The following is a description of a gene set: studied in species Homo sapiens The process whose specific outcome is the progression of a nerve over time, from its formation to the mature structure. Human Gene Set: GOBP_NERVE_DEVELOPMENT, and this is the list of marker genes: SIX4, CITED2, NAV2, HOXB3, GLI3, LRIG1, HES1, NEUROG1, NPR2, CHD7, GABRB3, EPHB1, BDNF, SLC1A3, EDNRA (NCBI Gene Id 1909), EGR2, GABRA5, NAGLU, AFG3L2, SLC24A4, EPHB2, HOXB2 (homeobox B2), SLC25A46, KCNQ3, ILK, NRTN, NGFR, CNGB1, NDP, TBX1, PLXNA3, VCAM1, SLITRK6 (SLIT and NTRK like family member 6), LPAR1, B4GALNT1, DRGX, CTNNB1, FBXO45, DAG1, ATOH7 (atonal bHLH transcription factor 7), KCNA2, NGF, NRP2, POU4F1, PRKCG, PHOX2A, SULF2, NKX2-2, SCN1A, ERBB3, KCNC2, ISL1, POU4F3, PHOX2B, SIX1, SULF1, LARGE1, ACKR3, SEMA3F, LRIG2, DICER1 (dicer 1, ribonuclease III), ECE1, PLXNA4, HOXA3, SLC38A8, HOXA1, NTRK1, ADARB1, EPHA4, CHRNB2, ATP8B1, SALL1, PAX2, KCNC1, NTF4, EDN1, TCIRG1, NRP1, RPL24, HOXB1, TFAP2A, COL25A1, NPTX1, PLXNA1, GABRB2, SERPINE2, HOXD3, LRIT3, DCANP1, ITGA4, TIFAB, EXT1, TMEM126A, NTF3, MAFB, ARK2C, SEMA3A